The following is a description of a gene set: Human Gene Set: ZHAN_MULTIPLE_MYELOMA_MF_UP To better define the molecular basis of multiple myeloma (MM), we performed unsupervised hierarchic clustering of mRNA expression profiles in CD138-enriched plasma cells from 414 newly diagnosed patients who went on to receive high-dose therapy and tandem stem cell transplants. Seven disease subtypes were validated that were strongly influenced by known genetic lesions, such as c-MAF- and MAFB-, CCND1- and CCND3-, and MMSET-activating translocations and hyperdiploidy. Indicative of the deregulation of common pathways by gene orthologs, common gene signatures were observed in cases with c-MAF and MAFB activation and CCND1 and CCND3 activation, the latter consisting of 2 subgroups, one characterized by expression of the early B-cell markers CD20 and PAX5. A low incidence of focal bone disease distinguished one and increased expression of proliferation-associated genes of another novel subgroup. Comprising varying fractions of each of the other 6 subgroups, the proliferation subgroup dominated at relapse, suggesting that this signature is linked to disease progression. Proliferation and MMSET-spike groups were characterized by significant overexpression of genes mapping to chromosome 1q, and both exhibited a poor prognosis relative to the other groups. A subset of cases with a predominating myeloid gene expression signature, excluded from the profiling analyses, had more favorable baseline characteristics and superior prognosis to those lacking this signature. Top 50 up-regulated genes in cluster MF of multiple myeloma samples with characteristic expression spike of MAF family transcription factors. from publication Zhan F, Huang Y, Colla S, Stewart JP, Hanamura I, Gupta S, Epstein J, Yaccoby S, Sawyer J, Burington B, Anaissie E, Hollmig K, Pineda-Roman M, Tricot G, van Rhee F, Walker R, Zangari M, Crowley J, Barlogie B, Shaughnessy JD Jr (PMID 16728703) species: Homo sapiens, and this is the list of marker genes: SFRP2, DEFB4A, GPM6B, PYGB, DOCK4, TYMP (thymidine phosphorylase), TMEM37, MCTP1, CD109, CDH1, DPYSL2, MGAT5, NUAK1, SMARCA1, CX3CR1, RNASE6, WHRN, SYNDIG1, APOBEC3A, FAM174B, SLC25A20, ITGB7, TLR4, AGMAT, SETBP1-DT, RASSF4, COTL1, NTRK2, TMEM255A, ABLIM1, MFAP2, ARHGAP6, CEBPD, CCDC86, SHMT1, SPP1, ARID5A, ABHD12, LCP2, PEBP1, ATP13A2, TUBB2B, TMPRSS15, TRIM47, GREB1, CXCL12, ARPC1B, NMU